Given this list of marker genes TAS2R4, RTP4, LPO, TAS2R7, TAS2R43, CA6, RTP5, GNAT2, RTP1, TAS2R13, TAS2R14, CST4, TAS2R42, TAS2R40, GNAT1, GNAT3, TAS2R16, TAS2R46, ITPR3, TAS2R41 (NCBI Gene Id 259287), PIGR, REEP2, PIP, TAS2R19, TAS2R1 (NCBI Gene Id 50834), CALHM1, PLCB2, TAS2R5, RTP2, TAS2R20, AZGP1, TAS2R50, TAS2R38, CST1, CST2, TAS2R3, TAS2R31, RGS21, TAS2R45 (taste 2 receptor member 45), RTP3, TAS2R9, TAS2R10, TAS2R39, TAS2R30, TAS2R60, TAS2R8, here is a description of the gene set: species: Homo sapiens Human Gene Set: GOBP_SENSORY_PERCEPTION_OF_BITTER_TASTE The series of events required to receive a bitter taste stimulus, convert it to a molecular signal, and recognize and characterize the signal. This is a neurological process.